Given this list of marker genes EMILIN1, PLAT, THBS1 (thrombospondin 1), SERPINE1, HPSE, NFE2L2, CD36, TBXA2R, USF1, HRG (histidine rich glycoprotein), PSEN1, F7, APOH, PLAU, SERPINF2, ANGPT1, VTN (vitronectin), ST3GAL4, THBD, F2R, ENPP4, F3, F12, ANO6, ANGPT2, EMILIN2, PRDX2, F2, PLG, VKORC1, here is a description of the gene set: Any process that activates or increases the frequency, rate or extent of coagulation. Human Gene Set: GOBP_POSITIVE_REGULATION_OF_COAGULATION species: Homo sapiens